Given this list of marker genes CKS1B, APPBP2-DT, ZNF276, PSMG3-AS1, RNF34, SFXN2, TMEM42, CLSTN3, GNG8, PXN-AS1, KPNB1-DT, PCBP2, SHC1, AGK, SNORD54, PTBP1, STAM2, EIF4ENIF1, BCDIN3D-AS1, MTHFR, NCKAP5L, ZNF687, CLCN6, PDE4A (NCBI Gene Id 5141), SMPDL3A, STAT3, MIR4479, KDM4B, AHNAK, STK11, KAT6A, KIF1B, ZNF606-AS1, MTG2, SNRNP25 (NCBI Gene Id 79622), CDK2AP2, PARP2, ZNF513, POLR3K, HERC4, MAPK1IP1L, TRNAU1AP, MAN1B1, PPIB, MTMR12, CDK2AP1, HNRNPA1, SRSF2, YJU2, NME6 (NME/NM23 nucleoside diphosphate kinase 6), MIDN, THOP1, APRT, TPM1, RPS20, ATP5ME, VASN, PTK2B, SPAG1, ARAP1, MIR3677HG, RAB4B, C5orf24, LINC03100, PGK1, MST1P2, MIR191, NLRX1, PDE8A, SLBP, TOB1, MIR3190, UQCC5, TOB1-AS1, SBNO2, HDLBP, PSMG3, CDK13, RNF135, FMNL1-DT, RGL1, PAK2 (NCBI Gene Id 9106), CNP, POLH, LINC01881, STRIP2, ACTN4, AP2A1, SAFB2, GTF2I, APPBP2, TRAF2, MIR124-3, JMJD4, SAMD11, TRMU, SIGIRR, UNG, RAB40C, EIF4A1, FAM117A, TTLL1, LRR1, UBALD2, SFXN3, HDGF, CIC, BAZ1B, DYNC2I2, TUBB4B, HOXB9, HDGFL2, DMWD, CNIH2, RELT, UBE2I, AP1S2, UIMC1, KLF10, INKA1, EIF5, TMEM219, SRPRA, RPLP0, NOP14, EXD3, RN7SL1, CCDC40, DALRD3, CRYZL1, EIF2D, NOXA1, ADAT3, GRK4, RPS29, TIMM22, CERNA3, MIR4492, TRIM35, TUBD1, RAB4B-EGLN2, RSAD1, MAN1B1-DT, GADD45B, COTL1, ACTR1B, DIP2A, ZNF687-AS1, TBC1D16, USP9X, TONSL, SAFB, COPS7B, SREK1, ZNF451-AS1 (NCBI Gene Id 101927211), PDZD7, TIGD5 (NCBI Gene Id 84948), SHARPIN, APTR, FMNL1, THRA, TMEM120A, ZFAND5, RSBN1L, TBC1D13, PCBD2, ISOC2, ZNF143-AS1, ABCA7, MAF1, FASN, SENP6, SAP30L-AS1, ZNF555, GLIS3, MAPRE3, DHX34, EEF1D, NAGLU, C2orf92, KMT5C, POLR2H, ARL3, ATG16L2, GBA1LP, QRICH1, USP20, HIP1, CROCCP2, PRKACA, RARA, C8orf58, FAM20C, CDK13-DT, PARN, GBA1, CANX, USP36, STARD7, FOXRED1, MAP4, KPNB1, DPCD, SCAMP4, WIPI2, PRORSD1P, ZMYM2, PNMA1, PER2, MARK3, KAT7, GOLGA5, GDI2, VPS37C, XPOT, MAP3K11, SNRNP70, VPS9D1, UBTF (NCBI Gene Id 7343), CLCN2, ACAP2, ZNF606, MYDGF, SLC35E2B, SEPTIN2 (septin 2), SLC26A6, ARPC5 (NCBI Gene Id 10092), SAP30L, PPP6R1, CCNDBP1, SNAP47, SMARCC1, NT5DC2, AGK-DT, MROH1, NDUFAF3, XPO5, PDE6D, RN7SL2, NOL6, LENG1, PLEKHH3 (pleckstrin homology, MyTH4 and FERM domain containing H3), ANAPC5, COMTD1, CIRBP, ZNF532, SSBP3, ZNF143, RNPS1, HECTD1, DDIT4, SERTAD2, RABAC1, KMT2A, C9orf78, SMOX, MFSD11, DNAJB1, SEMA7A, KDELR3, PXK, CIAO3, SRCAP, FANCA, RPL8, POLR2J4, MED13L, RPS6KB1, here is a description of the gene set: from publication Yevshin I, Sharipov R, Kolmykov S, Kondrakhin Y, Kolpakov F (PMID 30445619) Genes containing one or more binding sites for (PGM3) in their promoter regions (TSS -1000,+100 bp) as identified by GTRD version 20.06 ChIP-seq harmonization. Human Gene Set: PGM3_TARGET_GENES species: Homo sapiens